The following is a description of a gene set: Human Gene Set: DESCARTES_FETAL_CEREBRUM_VASCULAR_ENDOTHELIAL_CELLS from publication Cao J, O'Day DR, Pliner HA, Kingsley PD, Deng M, Daza RM, Zager MA, Aldinger KA, Blecher-Gonen R, Zhang F, Spielmann M, Palis J, Doherty D, Steemers FJ, Glass IA, Trapnell C, Shendure J (PMID 33184181) studied in species Homo sapiens Marker genes curated from the annotated cluster as represented in the Descartes Human Gene Expression During Development database. The gene expression program underlying the specification of human cell types is of fundamental interest. The study authors generated human cell atlases of gene expression and chromatin accessibility in fetal tissues. For gene expression, the study authors applied three-level combinatorial indexing to >110 samples representing 15 organs, ultimately profiling ~4 million single cells. The study authors leveraged the literature and other atlases to identify and annotate hundreds of cell types and subtypes, both within and across tissues. Our analyses focused on organ-specific specializations of broadly distributed cell types (such as blood, endothelial, and epithelial), sites of fetal erythropoiesis (which notably included the adrenal gland), and integration with mouse developmental atlases (such as conserved specification of blood cells). These data represent a rich resource for the exploration of in vivo human gene expression in diverse tissues and cell types., and this is the list of marker genes: APLN, HBA2, RHOC, FABP4, C1QTNF1, RPS14P4, RPL41P2, MECOM-AS1, KCNJ8, RASD2, MEDAG, NIP7, C2CD4B, TMEM204, ACVRL1, SLC38A2-AS1 (SLC38A2 antisense RNA 1), CRIP2, IFITM3, LINC02512, SMG1P3, ACTN4, IFIT3, SPINK8, GJC2, ITM2A, MSMP, HIGD1B, RPL17P21, CDC42EP1, CYSLTR2, PRKCH-AS1, MEGF6, EEF1A1P5, NOSTRIN, EHD2, SLC51B, COX4I2, GIMAP4, JAML, TCF15, ID1, HYAL2, VEGFC, CCN2, JAG2, SMAGP, ARHGAP29, CAMTA1-IT1, ICAM3, NODAL, TCEAL9, ENSG00000253348, LINC02765 (NCBI Gene Id 124900415), OLFML1, TNN, CD27, LURAP1L, ETS1, LEF1, TIE1, NPIPB3 (nuclear pore complex interacting protein family member B3), MSX1, COL1A2, ZNF436 (zinc finger protein 436), PRELID1, ALX3, CGNL1, RBPMS, COL4A1, SNRPB, SLC7A5, BGN, RHOB, SPON2, LTF, PHETA2, FGD5, FGR, DLL4, SOCS1, IGFBP7, CD93, SEPTIN4-AS1, ADGRL4, HSPD1P6, RPS28P7, ZBTB42, CAV2, PLAC9, LRRC32, APLNR, PCBD1, TBX18, NKD2, SRARP, MIR126, FMO1, AURKAP2, HTRA3, MYD88, LGALS1, JPH2 (NCBI Gene Id 57362), PHLDB2, DACT2, MAP3K6, ITIH5, EOGT, TCF7, PLOD1, SLC39A8, SLC38A3, ANGPT2, LAMC1, FLVCR2-AS1, ITGA1, HRCT1, DIPK2B, ENSG00000272243, UNC5B, HEG1, SLC38A11, CD300LG, SLC14A1, NOTCH3, C11orf96, ADGRF5, ZAP70, PDE6G, VAMP5, ATP8B1, GIMAP1, LINC02043, FAM162B, TCIM, FOXS1, L1TD1, SLC39A10 (solute carrier family 39 member 10), FOXC2, RHOD, PGF, COL6A2, SLFN5, CCDC86-AS1, LINC02266, DPEP1, LINC00636, LINC02751, ERVMER34-1, SRPX2, TNFRSF10A-DT, SNHG18, FCHO2-DT, CDH6, S1PR5, IGF2, BET1P1, RHBDL2, HMGB1P39, ZNF366, SIGIRR, SEMA3G, FOXF2-DT, SMG1P2, CDH5, TMEM176B, GIMAP6, DNASE1L3, ENSG00000269155, AADACP1, C4orf3 (chromosome 4 open reading frame 3), STARD8, ECSCR, SLC5A6, LINC02147, PTPRB, FOXL1, FZD4, MRPL17, SERPING1, PCOLCE, DKK1, IL10RB-DT, NOP10, C1QTNF12, ISM1, TDRD1, LINC02982, ANGPTL4, DEGS2, EMCN, CYP51A1P2, DOCK6, DLC1, EXOC3L1, RGS3, RPS28, SLC2A1, SLC52A2, COBLL1, BCAM, KANK3, ADCY4, LINC02091, CDC42EP5, DUSP6, EVA1B, OLFML2A, ADORA2A-AS1, TTN, ZNF593OS, IGFBP4, PCDH18, MPZL2, FLVCR2, PLXDC1 (NCBI Gene Id 57125), CLEC11A, SLC12A7, TBX2, OAS2, MYO10, MTCO2P12, SOX18, CSTB, HIC1, RPS14P5, LINC00840, PROCR, ITGA11, FAM43A, SULT1B1, FZD6, ELK1, SLC22A10, LEF1-AS1, TFRC, FAM110D, SPARC, GPR4, ENSG00000228157, SELE, ENSG00000205414, HSPB1, SLC16A1, IQSEC3-AS1, SLC16A4, HTR1F, SOCAR (NCBI Gene Id 105373557), FAM124B, SLCO1A2, ALX4, NQO1, RPS26P28, ATP10A, TRGC1, LCIIAR, TBX1, EPAS1, EDN3, LINC01132, LDLRAD2, MOCS1, EDN1, CALHM2, C1orf115, MT1F, NOS3, ENSG00000255462, CDKN2B, CAVIN1, STRA6 (NCBI Gene Id 64220), RRAGA, S100A10, TBX15, CBX2, QPCT, RPL12P4, FENDRR, CTSK, TGM2, HELZ2, ERG, TINAGL1, LINC02148, DDT, CLEC1A, CCDC86, CLIC2, MT1E, CD34 (NCBI Gene Id 947), ICA1-AS1, NIBAN2, BTNL8, ERVH48-1, CLIC5, RUNX3, ADGRF5-AS1, LYPD3, MOB2, CCDC85B, HMCN1, CLEC14A, CRIPTO, HSPA12B, GBP6, F2RL2, FOXO4, UACA, AVPR1A, LINC02058, MYL12-AS1, NHERF2, MT2A, SH2D3C, HID1-AS1, PPM1H (protein phosphatase, Mg2+/Mn2+ dependent 1H), PART1, SLFN12L, RP1, DEPP1, CLEC3B, ANXA1, RN7SL69P, A4GALT, CDC42EP2, BTNL9, FOSL2, ITGA2-AS1, NPIPB4, RGS5, DSP-AS1, DYSF, PRKCH, MCAM, CCM2L, TNKS1BP1, TMEM92, SPTA1, NTRAS, SP6, RTL8B (retrotransposon Gag like 8B), C20orf202, KIF26A, CARMN, ENSG00000272789, CAV1, PCDH12, LINC00607, NKX3-2 (NK3 homeobox 2), ST6GALNAC1, SPAAR, TNFAIP1, APOL3, SLC5A4, DCN, B3GNTL1P1, PYGO2-AS1, S1PR3, PIM3, RNU6-880P, KCNE4, HBB, RBP1, PLEK2, MYLK2, FOXL2, MYZAP, RIN1, XRCC6P5, CDK2AP2, CD79B, SYDE1, IFI27, STAP2, SOX17, MIXL1, FILIP1, SIX1, CXXC1P1, ACTA2 (NCBI Gene Id 59), ITPRID2-DT, ANAPC1P4, ALDH3A1, CASP12, TAGLN, SOCS3, ENSG00000243008, SMIM10, PCAT19, KLF11, ARF6, KCNJ2, FRZB (NCBI Gene Id 2487), AFAP1L1, SHROOM1, GATA2, TMEM88, GPER1, PRND, LINC02836, KLF10, CSAG1, TEK (NCBI Gene Id 7437), LMCD1, MDP1, CASP4LP, EIF3I, MYOM2, COL4A2-AS2, UBL4B, WWTR1-IT1, LINC02126, EDNRA, GGT5, CD19, TRGC2, MT1X, RELA, OCLN, NAMPTP1, HMGN1P13, ZNF703, USHBP1 (USH1 protein network component harmonin binding protein 1), FN1, VWA1, ADORA2B, NUP153-AS1, SLCO2A1, AOC3 (NCBI Gene Id 8639), TBX2-AS1, CCDC3, ABCA4, AGRN, WASF4P, COL18A1, CLEC2B, PRELP, CRIP1, ADA, LAYN, LMOD3, SNAI2, PRX, LAMC3, MXRA5, ARAP3, DSP, GATA2-AS1, VWA2, SLC7A1, ADM, RGCC, KDR, PTGDR2, SH3TC2-DT, HEYL, SYNM, SLC40A1, LSR, FOXQ1, FOXF1, OSMR, MECOM, CYYR1, EFNA1, S100P, IL17B, TM4SF18, TNFSF15, OR51E1, KLF2, GPRC5C, PDGFRB, RPL10AP2, LINC02507 (long intergenic non-protein coding RNA 2507), EPHA2, FOXF2, MELTF, TM4SF18-AS1, IFI6, LINC01139, LINC01391, IFITM1, TMEM45B, S1PR4, CFH, PCDH1, FOXC1, C1orf54, PPIC, FRK, PHLDA2, ROBO4, ITPR3, ARHGEF35-AS1, LRRC55, WWTR1, LUM, COL3A1, CD109, ZNF503, ATP5MC3, ANPEP, MMRN2, ACE, CETP, NOTCH4, LINC01644, FLT4, ID3, CARD8-AS1, RASAL2-AS1, CD248, SERPINH1, MUSTN1, TWIST1, CCDC141, F2RL1, LMO2, SOX7, KLF4, WDR86-AS1, CD320, OR2A1-AS1, CFP, ENSG00000233461, SLC7A5P2, VDAC2P5, FOXD1-AS1, RRAS, SIK1, ASB9, CIMAP1D, ST6GALNAC4, ENSG00000223786, SLC6A12, KANK4, INS-IGF2, EML3, SLC52A3, FHL3, PLEKHF1, THBD (NCBI Gene Id 7056), LIMS2, ENSG00000258926, STC2, NHSL2, OCEL1, CAVIN3, TMEM200B, TPT1P15, RPL13P12, ENSG00000251661, GRAP, NRARP, CRYBB3, TM4SF1, SLC6A13, IGFBP1, LINC03033, ENSG00000235834, ABCC9, ISG15, FSTL1, TMEM141, RPSAP11, SULT1E1, TNFRSF4, SLC30A1, TMEM37, AHNAK, ADORA2A, COL4A2, LINC02172, APOL4, GIMAP7, LINC00877, LAMB2, CXCL12, TNXB, ABCB1, TMC4, RPL7P23, XPNPEP2, THSD1, ITGA4, CDA, ROM1, ABCA9, PREX2, ARHGEF15, OAS3 (2'-5'-oligoadenylate synthetase 3), JCAD, NAALADL1, LINC01612, SAMM50 (NCBI Gene Id 25813), PTH1R, RASL12, LINC02208, CARD10 (caspase recruitment domain family member 10), S100A16, C8orf58